The following is a description of a gene set: studied in species Mus musculus Mouse Gene Set: GOBP_EPIDERMAL_CELL_DIFFERENTIATION The process in which a relatively unspecialized cell acquires specialized features of an epidermal cell, any of the cells making up the epidermis., and this is the list of marker genes: Mafb (MAF bZIP transcription factor B), Lce1a2, Wnt16, Gdf3, Zfp36, Fosl2, Kazn, Krt84, Abca12, Jag2, Kcnq1, Bmp4, Pdzd7, Stfa3, Alox8, Smarca4, Reg3a, Krt7, Csta2, Dnase1l2, Gfi1, Epha2, Pax6, Ovol2, Gli2, Gata6, Sprr2f, Wdpcp, Tmem132e, Hey2, Krt78, Foxn1, Clrn2, Klf4, Krt82, Bcl11b, Stfa2l1 (NCBI Gene Id 268885), Stk4, Sprr1a, Pphln1, Psap, Nfkbiz, Fgf20, Slc4a7, Cers3, Rac1, Kcnma1, Numa1, Ovol1, Mcoln3, Fgf2, Krt86, Pafah1b1, Lats2, Sav1, Cstdc5, Ripor2, Rest, Myo6, Sprr2b, Krt72, Krt77 (keratin 77), Slc44a4 (NCBI Gene Id 70129), Zfp36l1, Esrp1, Loricrin, Tecta (tectorin alpha), Whrn, Gm5478, Cstdc3, Dlx3, Krt74, Ptprq, Ercc2, Slc39a2, Exph5, Triobp, Alg10b, Hes5, Lce1g, Yap1, Krtap6-5, Krt83, Hdac2, Myo7a, Clrn1 (clarin 1), Scel, Tgfb2, Dsp, Krt4, Strc, Tgm1, Pou3f1, Cstdc6, Macroh2a1, St14, Vdr, Prkch, Ercc3, Ift74, Hes1, Bcr, Hoxa7, Clic5, Maff, Notch1, Acer1, Cdh3, Krt17, Map2k1, Slitrk6, Anxa1, Mycn, Errfi1, Gli1, Grhl2, Il17a, Krt5, Hey1, Txnip, Sod1, Cnfn, Minar2, Klf7 (NCBI Gene Id 93691), Mycl, Krt79, Sprr2d, Krt75, Krt80, Pls1, Cyp26b1, Sprr4, Atoh1, Dsg4, Grxcr2, Cdh23, Evpl, Trp63, Ptgs1, Fam3c, Sprr2i, Foxi3, Sgpp1, Ptch1, Sharpin, Krt81, Asah1, Sprr3, Ovol3, Krt76, Srsf6, Ush2a, Rock1, Mafg, Ivl, Sprr2g, Cyp27b1, Scrib, Krt10, Plec, Krt71, Gprc5d, Tsg101, Tgm3, Pkp1, Dll1, Sec24b, Cd109, Krt36, Csta3, Keap1, Casp3, Krt90, Csta1, Sprr2k, Foxc1, Sult2b1, Lhfpl5, Krt16, Krt1, Krt85, Tfap2a, Ubn1, Grxcr1, Fgfr3, Macroh2a2, Mir450b, Ppp3ca, Ush1c, Tmc1, Cux1, Tfap2c, Rock2, Stfa1, Ppl, Pou2f3, Hrnr, Ezh2, Cdsn, Mir96, Pcdh15, Fgfr1, Krt2, Spink5, Kdf1, Lats1, Reg3g, Sprr1b, Ankrd24, Myo3b, Nme2, Sprr2h, Atp2b2, Krt6b, Cdkn2a, Med1, Clic4, Msx2, Rbpj, Nherf1 (NCBI Gene Id 26941), Wnt5a, Opn3, Ugcg, Il1a, Jag1, Tmem79, Gsdme, Madcam1, Pou4f3, Hdac1, Elmod3, Irf6, Fa2h, Cstdc4, Gm5414, Ptgs2, Sfn, Tprn, Krt6a, Cdkn1a, Myo3a, Grhl1, Stfa2, Intu, Sfrp4, Flnb, Pnpla1, Tomt, Lamc1, Krt73, Gsdma3, Krt14, Extl3, Ncoa3, Palld, Gak, Sprr2e, Ptch2, Krt87, Etv4